Given this list of marker genes TGIF1, SHH (NCBI Gene Id 6469), NOG, CFC1B, ACVR1C, TGIF2, CRIPTO, DAND5, SMAD3, NOMO3, NODAL, ACVR1B, NOMO1, SMAD2, DACT2, DMRT1, FOXH1, NCLN, CRIPTO3, CFC1, CITED2, DACT1, here is a description of the gene set: Human Gene Set: GOBP_NODAL_SIGNALING_PATHWAY studied in species Homo sapiens The series of molecular signals initiated by nodal protein binding to an activin receptor on the surface of a target cell, and ending with the regulation of a downstream cellular process, e.g. transcription.